Given this list of marker genes Tnf, Grin2d, Aifm1, Tmbim6, Gria1, Hcn1, Pcna, Lmnb1, Hpca, Tuba1a, Ufl1, Prkn, Ghsr, Baiap2, Igf1r, Kcnb1, Fyn, Amigo1, Abcb1a, here is a description of the gene set: species: Mus musculus Any process that results in a change in state or activity of a cell or an organism (in terms of movement, secretion, enzyme production, gene expression, etc.) as a result of an L-glutamate stimulus. Mouse Gene Set: GOBP_RESPONSE_TO_L_GLUTAMATE